The following is a description of a gene set: Mouse Gene Set: GRAESSMANN_APOPTOSIS_BY_DOXORUBICIN_DN species: Mus musculus from publication Graessmann M, Berg B, Fuchs B, Klein A, Graessmann A (PMID 17160024) Impairment of the complex regulatory network of cell death and survival is frequently the reason for therapy resistance of breast cancer cells and a major cause of tumor progression. We established two independent cell lines from a fast growing mouse breast tumor (WAP-SVT/t transgenic animal). Cells from one line (ME-A cells) are sensitive to apoptotic stimuli such as growth factor depletion or treatment with antitumor agents (e.g. doxorubicin). Cells from the second line (ME-C cells), which carry a missense mutation at the p53 codon 242, are very insensitive to apoptotic stimuli. Co-cultivation experiments revealed that the ME-C cells mediate cell death resistance to the ME-A cells. Microarray and Western blot analysis showed that osteopontin (OPN) is selectively overexpressed by the ME-C cells. This glycoprotein is the most abundant protein secreted by the ME-C cells and we obtained strong indications that OPN is the main antiapoptotic factor. However, the OPN containing ME-C cell medium does not alter the expression level of pro- or antiapoptotic genes or known inhibitors of apoptosis (IAPs). Its signaling involves mitogen-activated protein kinase (MAPK)/extracellular signal-regulated kinase (ERK) kinase (MEK)1/2 as the kinase inhibitor PD98059 restores apoptosis but not the Akt inhibitor. In the ME-A cells, mitochondrial cytochrome c release occurs with and without external apoptotic stimuli. OPN containing ME-C cell medium does not prevent the mitochondrial cytochrome c release and caspase-9 processing. In serum starved ME-A cells, the OPN containing ME-C cell medium prevents caspase-3 activation. However, in doxorubicin-treated cells, although apoptosis is blocked, it does not inhibit caspase-3. This indicates that the ME-A cells distinguish between the initial apoptotic stimuli and that the cells possess a further uncharacterized control element acting downstream from caspase-3. Genes down-regulated in ME-A cells (breast cancer) undergoing apoptosis in response to doxorubicin., and this is the list of marker genes: Snord22, Tia1, Tcf3, Ppp4r3b, Pfkp, Tes3-ps, Ipo8, Erc1, Galk1 (NCBI Gene Id 14635), Coa5, Hbp1, Rrm1, Paics, Ambra1 (NCBI Gene Id 99255), Foxj3, Hp1bp3, Lmbrd1, Nfix, Adam17, Foxm1, Eif5b, Cxadr, Sox12, Stag2, Kdelr1, Ptprf, Rccd1, Fxn, Rassf8, Wdr4 (WD repeat domain 4), Dhrs4, 9430015G10Rik, Myo10, Fer, Msrb2, Kif1b (kinesin family member 1B), Pdgfra, Traf6, Phka2, Dnajb12, Ak3, Acot10, Cela1, Parp16, Armcx1, Tubb5, Ogt, Fto, Ccdc43, Mbd3, Pum2, Vps72, Ahctf1, Rnf111, Snx9, Rrbp1, Smr2, Cbl, Smarcad1 (SWI/SNF-related, matrix-associated actin-dependent regulator of chromatin, subfamily a, containing DEAD/H box 1), Myoc, Uba3, Coq5, Prpf31, Nr3c1, H1f4, Tcof1, Rbfox2, Asb7, Map4k5, Srsf1, Cpt1b, Lrba, Tmem209, Fbxl8 (F-box and leucine-rich repeat protein 8), Stoml2, Zbtb20, Ipo11, Pkp4, Psmg1, Myb, Nagk, Lclat1, Pard3, Zfp422, Mrpl15, Acaa2, Swap70, Ikbkg, Psmg4, Slc6a2, Spred1, Suclg2, Tm9sf3, Sirt4, Cdca7l, Mmab, Slc7a2, Pum3, Ddx17, Dhx9, Hipk2, Mthfs, Tomm40, Zfp277, Cip2a, Foxf1 (forkhead box F1), Daglb (NCBI Gene Id 231871), Srsf7, Zfp322a, Hars2, Slc12a6, Kmt2c, Lysmd3, Stag1, Prkcz, Efcab2, Magi3, Cfap141, Bet1, Mrpl42, Nipsnap3a, Nfatc1, Pstk, Zfp91, Rrp8, Dusp22, AU020206, Apbb2, Nfic, Kri1, Klhl7, ENSMUSG00000142832, Rassf1, Rab4a, Slc44a2, Tcp1, Tmem135, Kmt2a, Trim44, H2-T13, Gphn, Cop1, Gcsh, Kpnb1, Zscan22, Kmt5b, Commd1, Mtmr4, Hspa8, Zdhhc3, Ipp, Agap1, Oxnad1, Sptan1, Add3, Eid1, Itsn2, Nr1d2, Ppp2r1b, Coil, Ptpn21, Anapc11 (anaphase promoting complex subunit 11), Sh3bgrl, Smim11, Fuom, Aldh18a1, Scamp4, Mllt3, 0610010K14Rik, Ola1, Mfsd4b1, Zbtb22, Osbpl9, Col12a1, Ptch1, Ank, Papola, Sec16b, Lyplal1, Rabggta, Jtb, Atp6v0a1, Lactb2, Fbf1, Tpk1, Chek1, Chd1, Hmbs, Stx17, Olfml2b, Zfp318, Htatsf1, Gatb, Dip2b, Foxc1, Kat7, Plekhf1, Fermt2, Rasl12, Rhot2, Nbea, Chml, Ghdc, Elac2, Slc19a1, Hsd3b7, Klf13, Runx1, Cyp51, Glg1, Dlx5, Porcn, Ap5m1, Etl4, Dtymk, Itgb3bp, Ccdc9, Sox6, Magohb, Rdx, Nrf1, Herc4, Elp4, Scaf8, Rbm10, Tnrc6b, Chek2, Slfn2, Dbn1, Pola1, Nedd4l, 4833420G17Rik, Thsd1, Rnf13, Gtf2ird1 (NCBI Gene Id 94276), Tcp11, Wdr87-ps, Myadm, St3gal1, Lmbr1, Faah, Slc44a3, 2310030G06Rik, Arhgef12, Slc30a6 (NCBI Gene Id 78426), Mbtps1, Snhg6, Diablo, Fdft1, Psip1, Bcl2 (NCBI Gene Id 98734), Rab2a, Trmt112, Spry1, Scd2, Arhgap6, Lgalsl, Ilkap, Nuf2, Rnf141, Med12, Efhd1, Acvr1, Dmac2, Cep131, Ncapd2, Prxl2c, Slc4a3, Sbf2, Cadm1, Atg5 (autophagy related 5), Myo1e, Osbpl6, Dcaf8, Per2, Brd8, Mfsd4b2, Plpp3, Prkdc, Nek3, 1810030O07Rik, Hip1, Gnl1, Lancl2, Sil1, Xrcc4, Babam2, Pole, Trib3, Cxxc1, Arhgef10, Map4k3, Plekha5, Zfp280c, Rbl1, Hnrnpd, Ube3a, Ercc4, Cdca7, Mbd2, Racgap1, Chd4, Mnt, Hnrnpdl, Ppargc1b (NCBI Gene Id 170826), C1qbp, Metrn, Pigc, Hmga2, Orc3, Atp10a, Rhou, 2310061I04Rik, Tbc1d17, Kat2b, Vangl2, Vrk3, Mgst3, Osmr, Mrpl58, Map3k1, Cnot1, Polr1h, Mtss1, Pld1, Srgap2, Xpo7, Ttc5, Zcchc8, Thrap3, Efr3a, Dgcr8, Hsd11b1, Asph, Timm44 (translocase of inner mitochondrial membrane 44), Dap, Rgs19, Ppp3cc, Xpa, Brwd1, Nolc1, Homer2, Rabggtb, Rpl41, Mrpl50, Iqcc, Nsmce1, Ptprs, Immt, Sqle, Dhx36, Sfr1, Caprin1, Mapk3, Dimt1, Ercc6l, Sppl3, Ube2j1, Trp53i13, Nono, Ccdc91, Brcc3, Dhcr24, Coa7, Tspan5, Zkscan3, Dhodh, Slc44a1, Coq8a, Bicc1, Tmem80, Tnpo3, Ppil4, Myod1, Steap3, Sod2, Rfk, Pdk2, Deptor, Trio (triple functional domain (PTPRF interacting)), Atxn2, Dmp1, Elp3, Bbs9, Aqp5, Cnot4, Chmp1b2, Aatf, Zfp790, Sesn1, Cntln, Pdss1, Eif4e2 (eukaryotic translation initiation factor 4E member 2), Cyp24a1, Qrich1, Ttc28, Traf2, Kpna3, Raver1, Nicn1, Cops7a, Phf21a, Adamts5, Polr2i, Msmo1, Fyn, Dusp19, Bcl3, Gtpbp2, Pcf11, Map3k5, Mvk, Gpr137b, Rreb1, Peak1 (pseudopodium-enriched atypical kinase 1), Aoc3, Dhcr7, Cnot2, Ppp3ca, Spart, Hmgcs1, Mkks, Pck2, Zfp704, Ier3, Mtmr2, Ndufb4, Myof, Tars2 (NCBI Gene Id 99622), Ptrhd1, Dock1, Limch1, Vti1a, Kmt2e, Fosl2, Dyrk1a, Il6st, Pds5a, Mepce, Zfp68, Pbk, Rpp14, Mad2l2, Gemin6, Hnrnpa1, Uck2, Cradd, Fktn, H1f0, Ralgapa1, Nudcd3, Efna4 (ephrin A4), Fbxw11, Nudt21, Gdi1, Sfxn4, Rbm26, Dynlt1b, Mga, Npm1, Stx4a, Nfkb1, Tbl1xr1, Brca2 (NCBI Gene Id 12190), Abcc1, Myorg, Lss, Tenm4, Twf1, Tmpo, Serpinb1a, Ubl4a, Mdfi, Epb41l2, Cpne1, Septin10, Tle6, Epha4, Plp2, Edem3, Limk1, Slc25a24, Rsrc2, Galnt2, Slain2, Eif4b, Pak1 (p21 (RAC1) activated kinase 1), Odr4, Crk, Far1, Ptbp3, Lims1, Smarcb1, Psenen, Suz12, Angptl6, Zbtb46, Lrrc58, Tmem106b, Cilk1, Cdc42bpa, Rad23a, Tdp1, Egln1, Pias2, Tubb2b, Klhl5 (kelch-like 5), Elac1, Mtdh, Nek7, Wasl, Ift122, Mpc1, Adat2, Ikbkb, Knstrn, Gsr, Snx5, Ube2c, Dek, Vps35l, Cbx8, Sec14l1, Igfbp2, Mospd2, Abhd17c, Slc9a8, Tcf7l2, Zfp82, Cdkal1, Hspa9, Pard6a, Polr3g, Smyd2, Mapkap1, Mios (meiosis regulator for oocyte development), Pum1, Nrm, Cbx6, Pla2g15, Erg28, Chm, Trib1, Fmo1, Tefm (transcription elongation factor, mitochondrial), Adat1, Gna12, Nt5e, Zscan12, Senp1, Usp9x, Sae1, Rif1, Gnb1, Tti2, Pik3c3, Zfp467, Jarid2, Msra, Cyb5b, Wnt5a, Alkbh4, Adk, Ppat, Fubp1, Boc (BOC cell adhesion associated, oncogene regulated), Lta4h, Apex1, Elovl6, Igf2bp2, Klf7, Cnn3, Mettl22, Prmt2, Bean1, 2700097O09Rik, Adissp, Zfp142, Fanca, Btbd3, Nsun4, Erlin1, Nubp1, Rbm39, Atf6, Nedd4, Ap2b1, Spdef, Tmem161a (transmembrane protein 161A), Snrnp40, Srprb, Polm, Mboat1, Galnt7, Zbtb14, Acin1, Prim2, Prpf39, Utrn, Calm3, Ndst1, Timp3, Ncaph, Dazap1, Sarnp, Afg3l1, Brat1 (NCBI Gene Id 59292), Grb14, Spag7, Ccdc102a, Rnf145 (ring finger protein 145), Tada3, P2ry2, Zbed3, Ctdspl, Clock, Slc35a3, Speg, Retreg1, Lbr, Klf6, Smc6, Rcc1l, Adnp, Thap12, Mllt10, Naga, Usp36, Msh3, Cnot6, Kics2, Ubxn6, Srek1, Epc1, Prpsap1, Cntn1, Thoc2, Lyst, Tctn3, Hnrnpu, Anxa6, Rabgap1l, Cep152, Nfatc3, Fzr1, Skp2, Steap4, U2af1l4, Zfp212, Prkacb, Tmem179b, Srsf6, Syncrip, Khdrbs1, Trim16, Pomk, Rad51c, Mtbp, Ddx3x, Elf5, Cyb5r1, Tspan2, Cnot7, C1d, Bccip, Commd2, Trim2, Top2a, Col3a1, Rfc1, Mtf2, Oxsm, Tfap4, Snx14, 3110040N11Rik, Rpl22l1, Keap1, Rdh14, Foxn2, Sin3a, Stx12, Gng12, Capn6, Ranbp1, Dcps, Prnp, Il17rc, Cyp2c55, Nsfl1c, Eif4a1, Papss1, Cttn, 5830417I10Rik, Rab18, Dna2, Clpp, Dusp12 (NCBI Gene Id 98654), Pot1a, Sf3b3, Reck, Txnip, Tmem186, Nop10, Ncapg2, Dctpp1, Rap1gds1, Pipox, Atg10, Cavin3, Mccc2, Hspbp1, Zbtb7b, Stx8, Sfxn1, Clk4, Mcrs1, Thrsp, Csde1, Tpm3, Rpl3, Ntng1, Hlf, Rbm14, Nsmce2 (NSE2/MMS21 homolog, SMC5-SMC6 complex SUMO ligase), Ppp1cc, Nutf2, Birc6, Phldb2, Mrrf, Ankrd17, Itga5, Ccnq, Atad1, Dgcr2, Dlk2, Usp34, Smc5, Yes1, Pdap1, Mtmr3, Runx2, Pcbd2, Cd2ap, Rab4b, Ncor1, Pdgfrb, Rita1, D2hgdh, Zfp445, Atp6v0a2, Tacc2, Prpf38b, Smarca2, Ensa, Bnip3l, Plk4, Ppp4r3a, Ctcf, Exoc4, Lzts2, Ezh1, Cask, Rpl22, Ube2e3, Kif4, Creb1, Paxip1, Nr1i3, Ddx6, Zfp84, Slc4a4, Nrip1, Nup58, Tmem126a, Ptpn11, Tuba1a, Nop58 (NOP58 ribonucleoprotein), Apbb1, Farp1 (NCBI Gene Id 223254), Tle2, Raf1 (v-raf-leukemia viral oncogene 1), Dpagt1, Nop56, Dynlt3, Rnf130, Cap1, Bclaf1, AU040320, Pagr1a, Osr1, Rev3l, Lpcat1, Exosc2, Dmac1, Rimoc1, Xbp1, Reps1, Efna5, Zfp292, Pde8a, Ate1, Cebpg, Slc9b1, Gsdme, Id3 (inhibitor of DNA binding 3), Kdm4b, Tlcd1, Zfp638, Pcca, Sash1, Tgfbr3, Dcaf5, Cmbl (NCBI Gene Id 69574), Borcs5, Nup133, Mybbp1a, B230354K17Rik, Zbtb12, Gmpr, Fmr1, Fignl1, Atp1a2, Pafah1b3, Pcdhb21, Ptcd2, Trpm7, Mthfd2, Golim4, Lmnb2, Klhl24, Dtl (denticleless E3 ubiquitin protein ligase), Senp6, F2rl1, Phf13, Bcs1l, Pik3c2a, Irf3, D8Ertd738e, AI506816, Fbxw2, Mrtfa, Ube2g1 (NCBI Gene Id 67128), Lpp, Zfp148, Arglu1, Tifa, Cog1, Haus1 (HAUS augmin-like complex, subunit 1), Eef1akmt1, Pdha1, Marcksl1, Zcchc7, Car9, Dnph1, Egln2, Akr1e1, Qki, Cox16, Hnrnpl (heterogeneous nuclear ribonucleoprotein L), Ctdsp1, Bcl7b, Camk2d, Thra, Chst10, 3110009E18Rik, Tmem176a (NCBI Gene Id 66058), Pole2, Ap3d1, Trdmt1 (tRNA aspartic acid methyltransferase 1), Gid8 (GID complex subunit 8), Ripk1, Hspe1, Ctnnbip1, Sc5d, Kctd1, Wdfy3, Gabrb2, Slc25a13, Tha1, Uri1, Sergef, Tafa5, Tcf4, Nfya, Hectd1, Tcf19, Ptpra, Prkd3, Cep57l1, Pld2, Pura, Rcl1, Ubr2, Heatr1 (NCBI Gene Id 94251), Cul4b, H2ac7, Tpd52l2, Emp1, Timm10, Snai2, Nisch, Ube2d3, Zscan21, Tbrg4, Rlim, Ide, Chd7, Mydgf, Nf2, Tnfsf13, Usp4, Wdr82 (WD repeat domain containing 82), Tcerg1, Crlf2, Dennd11, 1190005I06Rik, Tns2, Acbd6 (acyl-Coenzyme A binding domain containing 6), Nup160, Frmd6, Kank2, Pcnx3, Plpp2, Clcf1, Wdr33, Tmem175, Txnrd3, Ache, Cox20, Fam220a, Fancc, Ap3m2, Sinhcaf, Srgap3 (SLIT-ROBO Rho GTPase activating protein 3), Fryl, Snx18, Nmt1, Dctn4, Coq3, Mapt, Nr2c2ap, Exosc10, Tars1, Atl3, Snhg8, Ltbp1, Ifrd2, Smyd5, Ufc1, Tbl1x, Kif3c, Tom1l1, Pafah1b2, Ccnh, Krcc1, Ptov1, Tmem144, Ergic1, Snd1, Ptms, Fbxo6, Bcdin3d, Atp2a2, Rrp15, Mdp1, Trf, Wwox, Huwe1, Cav1, Bckdk, Xpo1, Casc3, Tcf12, Bcl2l2, Armt1, Frmd4b, Hspb8, Pbx1, Bgn, Dsg2, Taf8, Cetn3, Polr3a, Abcd3, Cab39l, Bckdhb, Dst, Ddx19b, Letmd1, Coasy, Alg14, Myo1b, Marcks, Ctdsp2, Ccnt2, Pcm1, Spin1, Hmbox1, Ybx3, Enc1, Uba2, Fut8, Neurl4, Uqcc2, Ube2e2, Ogg1, Cebpzos, Rusf1, Dtnbp1 (dystrobrevin binding protein 1), Pde7a, Cgnl1, Kpna1, Clasp2, Slk, Adam10, Galnt4, Zscan26 (NCBI Gene Id 432731), Morf4l1, Diaph3, Pold1, E2f8, Gng5, Zfp706, Nup107, Zfp644, Chchd3, Angpt1, Baz2b, Hnrnpk, Mphosph10, Frs3 (NCBI Gene Id 93740), Grtp1, Rnf214, Oxa1l, Pank3 (pantothenate kinase 3), Mrpl17, Hcfc1, Nrp2, Stam2, Kcnk1, Rpa3, Rps19, Morf4l2, Utp25, P2rx4, Ivns1abp, Rusc2, Exosc5, Nsmce4a, Map3k4, Rngtt, Tomm5, Phf20, Trmt1l, Vcam1, Cdc7, Rpl30, Ppp2r3c, Vps54, Nck2, Phykpl, Ebpl, B9d2, Ssbp1, Mtap, Hdac7, Tmem268, Inpp5k, Usp47, Ski, Ckap5, Map6 (NCBI Gene Id 17760), St13, Ppih, Mnat1, Efl1, Rad54l, Me2, Mid1ip1, Tmem109, Rpp21, Suv39h1, Fzd2, Enox2, Cnot6l, Zfp386, Carmil1 (capping protein regulator and myosin 1 linker 1), Lrrc8c, Anln, Norad, Med16, Cul3, Tmem60, Ddr2, Kif2a, Hells, Snhg5, Pabir1, Yae1d1, Ophn1, Dock5, Sh3bp5, Rab9, Hdhd3, St7l, Spcs3, Lig3, Trib2, Dram2, Xiap, Rmnd1, Dpy30, Ssr1, Col1a2, Zfp101, Agfg2, Pex11a, Cdk5rap1, Tom1, Tsen15, Drg1 (developmentally regulated GTP binding protein 1), Tlr6, Zfpm1, Rbm25, Elovl5, Notch2, Parp2, H2-M3, Vav3, Acvr1b, Ptrh2, Bag5, Tmem39a, Eif4a2, Epn2, Gart, Gli2, Gpatch8, Pold2, Nherf2, Phip, Cox17, Hadh, Ears2, Epb41l4a, Nf1, Lrch4, Foxf2, Ankrd13b, Ndufs7, Wac, Arpc1b, Spop, Dcp1a, Ddi2, Mcmbp, Polr1d, Yeats4 (NCBI Gene Id 75922), Usp22, Foxk2, Ror1, Hexd, Pank1, Slc29a2, Polr1has, Acsl4, Rhbdd1, Atxn7l3, Dock9, Ndufaf7 (NADH:ubiquinone oxidoreductase complex assembly factor 7), Opa3, Dysf, Emg1, Cep41, Poli, Wdsub1, Srpk2, Asnsd1, 1700001G17Rik, Polb, 1110004F10Rik, Cenatac (NCBI Gene Id 382073), Tpbg, C1qtnf12, Hdac3, Hibch, Atp5mc1, Prelp, Mnd1, Gjc1, Crybg3, Pnn, Ints6, Sec24d, Stat5a, Saal1, Ube2s, Cd44, Seh1l, Smim10l1, Nkd2, Zdhhc5, Dlgap5, Fbxo4, Zmym6, Trip4, Mmachc, Nr2c2, Rce1, Ccdc50, Rab28, Ythdf3, Arl6ip5, Fjx1, Arhgap21, Plin3, Actr8, Rrp1b, Trpc2, Ghr (growth hormone receptor), Socs6, Slc39a11, Kansl1, Bnip3, Ttc14, Pafah1b1, Tanc1, Reep6, Map2k7, Arhgef10l, Cstf2, Zfp395, Tnrc6a, Borcs7, Notch4, Erbb2, Pex7, Rsrc1, Mcm2, Cdk2, Rab14, Scaf11, Zkscan6, Ilf3 (NCBI Gene Id 16201), Foxp1, Smarce1, Ppp1r3c, Phka1, Acacb, Dnajc13, Per3, Mtfmt, Csnk1d (casein kinase 1, delta), Cstf3, Washc4, Eva1a, Zdhhc6, Sgtb, Stard4, Pbrm1, Mutyh, Mrpl12, Casd1, Mrps28, Eef2k, Klhl36, Bicd1, Zfp207, Dbf4 (DBF4 zinc finger), Emp2, Pofut1, Etf1, Slc25a10, Acot9, Sdc3, Spred2, Gm5461, Mrpl23, Csnk2a1, Trps1, Mrpl32, Rnaseh1, Ormdl1, Actb, Zfp87, Hmgxb4, Trip13 (NCBI Gene Id 69716), Prelid1, Spats2, Dlat, Tmem79 (NCBI Gene Id 71925), Gmnn, Gatd3a, Tbl2, Ibtk, Tcf25, Nxt1, Lgals7, Fam118a, Vamp3, Pgls, Rad51b, Dhps, Tmem176b, Zfp398, Chac2, Camk2g, Ppp2r3a, Elmo1, Ttc8, Socs2, Prmt7, Son, Cdc73, Cdc6, Atrx, Arf6, Creld1, Fars2 (NCBI Gene Id 77901), Eri2, Scara5, Naa10, Dusp16, Pex14, Akap12, Slf2, Smad4, Bysl, Faim, Net1, Atp5mc2, Bcr, Ddx10, Ube2k, Fkbp11, Muc4, Erdr1, Eea1, Krtcap2, Gab1, Dusp11, Pik3r1, Nudt16l1, Amz1, Rilpl2, Jmjd8, Map2, Pou2f1, Sptbn1 (spectrin beta, non-erythrocytic 1), Btc (betacellulin, epidermal growth factor family member), Cebpb, Braf, Cfap97, Anapc1, Srsf3, Ap1g1, Rnf138, Zfp90, Gcnt1, Asap1, Plce1, Loxl4, Cptp, Cul2, Myg1, Nusap1, Itpr1, Cemip2, Stk3, Stat5b, Luc7l2, Exosc1, Dars1, Xpo4, Pimreg, Elk4, Hspa4, Apool, Gnpnat1, Tk1, Ywhaz, Minpp1, Mrpl3, Mrgprf, Numb, Atp11a, Rbbp9, Nectin2, Ehd2, Pals2, Gatad2b (GATA zinc finger domain containing 2B), Ahdc1, Mrps16, Usp21, Exoc6, Brd4, Plekhg5, Cbx1, Tbc1d19, Vcf1, Aak1, Wdr77, Kitl, Mettl27, Eri3, Rock2, Cxcl5, Cdk16, Pard6b, Rad21, Snrnp48, Strada, Ptbp2, Ndfip1, Mettl1, Fancm, Mrpl34, Trip11, Lox, Sh3kbp1, Ndufs8, Cbx3, Il15ra, Pakap, Alg12, Akap8, Eif2s2, Rad23b (NCBI Gene Id 78352), Ints7, Ten1, Mki67, Pabpn1, Msn, Tgfb2, Pak3, Spen, Got1, Mtch2, Grhl2, Mdn1, Chd1l, Gtf2i, Atp5f1c, Myo9a, Ets1, Zfand3, Lamc1, Rpap2, Kif5b, Vasp, Bex3, Stc1, Nfyc, Rcan3, Fech (NCBI Gene Id 14151), Zfp521, Casp2 (caspase 2), Dclk1, Wdr75, Pigp, Cbx5, Ip6k1, Vti1b, Pitpnb, Zfp93, Xpr1, Dennd1a, Itch, Hmgb2, Sepsecs, Arid4b, Bmpr1a, Isoc1, Nasp, Igfbp5, Pbx2, Cdk4, Cd200, Bbx, Ccl5, Kat2a, Cryzl1, Ash1l, Lmnb1, Zcchc14, Krba1, Bri3, Prune1, Tubgcp4, Ube4b, Ttc3, Hif1a (hypoxia inducible factor 1, alpha subunit), Taok1, Igf1r, Cyp4f13, Fancl, Fastk, Ocel1, Abce1, Ccdc127, Pask, Med25, Dnm1l, Rp2, Pmf1, Elk1, Svil, Cntf, Cachd1, Kras, Invs, Abcb7, Trak1, Thop1, Cnep1r1, Cep15, Phf12, Erbin, Ptprk, Bola1, Sesn3, Dlg1, Dhrs11, Kif11, Pcgf2, Cdc27, Zfhx3, Dhdds, Pold3, Elk3, Grk5, Dtx3, Ccni, Sphk1, Zfp768, Atp9a, Tnnc2, Myl6b, Pfkm, Nipbl, Il13ra1, Zfp282, Zmym3, Ext1, Etaa1, Magi1, Polr1b, Rab3d, Adamtsl5, Arhgap5, Sspn, Tsc22d4, Fdps, Iars1, Ubap2l, Tmem121 (NCBI Gene Id 69195), Fastkd2, Efhd2 (NCBI Gene Id 99974), Ttyh2, Ccn5, Sema6d, Pmpcb, Tmem167, Snhg16, Hjurp, Rufy3, Cep20 (centrosomal protein 20), Gpam, Timm9, Ndn (necdin, MAGE family member), Ube2w (NCBI Gene Id 66799), Tfrc, Ptpn12, Sertad3, Srsf2, Bnip1, Cdkn1b, Uqcc4, Clip2, Ptdss2, Ndufaf4, Bace1, Nras (neuroblastoma ras oncogene), Bpnt1, Anapc4, Man1a2, Hnf4a, Nt5c3b, Usp1, Mmgt2, Parn, Atm, Fndc4, Smim30, Pdk1, Gabpa, Rbm18, Shkbp1, Dcaf1, Gorasp2, Rabif, Snapin, Tmem216, Klf3 (Kruppel-like transcription factor 3 (basic)), Pigu, Suox, Dnajc24, Tbce, Mpdz, Tril, Sh3rf1, Clip1, Flot1, Gas5, Rpp40 (NCBI Gene Id 24016), Igf1, Neat1, Adck1, Carm1, Cd276, Ryk, Tyms, Supt20, Golph3, Hnrnpr, Pfkl, Timeless, Rhobtb2, Stat6, Aldh1b1, Pqbp1, Fads2, Ephb4, Farsb, Neil3, Pcmtd1, St3gal5, Bbs2, Rad18, Ubr5, Zfp771, Rbm5, Vangl1, Pde6d, Cert1, Slc39a3, Nap1l3, Dnajc14, Ctnnb1, Ift46, Gabbr1, Hikeshi, Cyp1b1, Phf3, Rttn, Ewsr1, Scd1, Col5a2, Czib, Tfb1m, Pts, Tpr, Sp3, Rbms1, Rock1, Fbxo21, Myc, Atf2, Anp32b, Pus3, Pcmtd2, Trub2, Ska1, Mapk8, Eef1e1, Mynn, Nfib, Slc23a2, Ddx39b, Cacna1a, Kansl2, Gdpd1, Aldoa, Lyrm2, Cuta, S100b (NCBI Gene Id 20203), 1810009A15Rik, Nelfa, Hmgb1, Vwa1, Mrpl40, Mapre2, Ywhah, Nudt2, Dph6, Lmf1, Aarsd1, Clybl (citrate lyase beta like), Cntrob, Fgfr1, Gsk3b (NCBI Gene Id 98033), Arrb2, Slc20a2, Tent2, Atxn7, Use1, Mrm1, Cat, Ccdc88a, Nudcd1, Zfp280d, Bin1, Dym, Zeb2, Osgep, Polr3f, Srgap1, Gmfb, Xrcc5, Pla2r1 (phospholipase A2 receptor 1), Phb1, Rilpl1, Wee1, Pygb, Stambpl1, Naa15, Srsf10, Ccsap, Col4a6, Rab27b, Tspan15, Capza1, Mrpl19, Fstl1, Zfp329, Srebf2, Mrps5, Fam3c, Ctbs, Toe1, Pigo, Hivep2, Ldlr, Insig2, Ubr1, Jdp2 (NCBI Gene Id 81703), Bloc1s5, Lrp6, Tmem168, Sult2b1, Taf1d, Pcbp4, Nrep, Nt5c, Fez2, Cdk5rap2, Ppdpf, Atf4, Mef2a, Snrpa, Gys1, Cav2, Mecp2, Vsx2, Il1r1, Clstn1, Arih1, Copg2, Hace1, Nudt4, Pdzrn3, Frrs1, Arfgef1, Iars2, Card19, Rai14, Ms4a8a, Alg3, Mdfic, Exosc7, Gpt2, Lamtor4, Bcl9, Elp2, Plscr1, Klhl20 (NCBI Gene Id 98385), 2010204K13Rik, Polr1a, Snx15, Gnao1, Fads1, Rgs11, Eci1, Pcid2